Given this list of marker genes C2CD3, TSEN54, NRCAM, NODAL, POLR1A, YY1, KRT5, FGFR1, GNPTAB, TSEN34, TSEN15, PIGY, RALGAPA1, RTL1, SHH, WDR26, AFF4, TCEAL1, PIGW, SON, DCHS1, FOXH1, CLCN6 (chloride voltage-gated channel 6), SIGMAR1, RNF13, DLL1 (NCBI Gene Id 28514), SPOP, CRIPTO, SPTBN4, CDKL5, KLHL40, TRIP4, PDHA1, SIX3, SPG11, COG5, PIGO, PRPS1, COL7A1, PGAP1, SPTLC1 (NCBI Gene Id 3302), FAT4, PGAP2, UBTF (NCBI Gene Id 7343), PGAP3, MGAT2, PTCH1, LRPPRC, TBCK, BRAF, GAS1, DNM1L, TGIF1, UGDH, MEG3, PNPT1, TRAPPC12, PTPN23, SCN1A, DEGS1, ACTA1, ITCH, ZIC2, PSAT1, STAG2, PLCH1, KRT14, CDON (NCBI Gene Id 50937), MTRFR, FUS, SMC1A, MECP2, DALRD3, TRIO, TSEN2, ADNP, PIGL, COL2A1 (NCBI Gene Id 444981), FGF8, MYO1H, SCN3A, AFG2A, GLI2, DLK1, SEPSECS (Sep (O-phosphoserine) tRNA:Sec (selenocysteine) tRNA synthase), ASPA, SYNE1, DPM1, SETBP1, PPP2R1A, CAMLG, TOR1A, LONP1, STIL, SLC5A6, FDFT1, BLM, CLN8, PIGU, ALS2, SLC1A4, DISP1, PIGV, ALG12, here is a description of the gene set: Human Gene Set: HP_GASTROSTOMY_TUBE_FEEDING_IN_INFANCY studied in species Homo sapiens Feeding problem necessitating gastrostomy tube feeding. Gastrostomy tube feeding in infancy